The following is a description of a gene set: Human Gene Set: GOCC_PEPTIDASE_INHIBITOR_COMPLEX studied in species Homo sapiens A protein complex which is capable of peptidase inhibitor activity., and this is the list of marker genes: CTSB, SERPINB6, SERPINE1, SERPINA5 (NCBI Gene Id 95024), CARD16, CSTA, VTN, PLAT, CASP1 (caspase 1), PLAU, KLK8